The following is a description of a gene set: studied in species Mus musculus Genes predicted to be targets of miRBase v22 microRNA mmu_miR_211_3p in miRDB v6.0 with MirTarget v4 prediction scores > 80 (high confidence targets). from publication Chen Y, Wang X (PMID 31504780) Mouse Gene Set: MIR_211_3P, and this is the list of marker genes: Atp2b3, Cacna1b, Satb1, Pabir2, Stox2, Fam78a, Arfgap3, Rapgef6, Mcph1, H2-Eb2, Tcf12, Ndufb3, Mylk4, Pank3, Kcnma1 (NCBI Gene Id 70528), Tk2, Tmpo, Plxnb1, Bcl11b, Zcchc2, Nab1, Snrnp27, Niban2, Irak1, Med1, Dnajc25, Gpr176, Gpr3, Oga, Rbm46, S100a3, Ube2w, Serf2, Ghitm, Dnase2b, Erp29, 4930426D05Rik, Cyp4v3, Wipf2, Rnf225, Dnal4 (NCBI Gene Id 54423), Pld1, Cyb5r1, Sirt7, Rab14, Nkd1, Fen1, C2cd3, Capn2, Hspa2, Wapl, Mtus2, Phf14, Prpf39, Kcnc2, Ppm1e, Rab12, Steep1, Rasgrf2, Minar1, Polr3k, Htr5a, Teddm2, Hmgb1, Hmbox1, Ppp1r3f, Btg2, Fancl, Actg1, Itgae